The following is a description of a gene set: studied in species Homo sapiens Human Gene Set: GOMF_PLATELET_DERIVED_GROWTH_FACTOR_RECEPTOR_BINDING Binding to a platelet-derived growth factor receptor., and this is the list of marker genes: VEGFD, IL1R1, PDGFA, ERN1, PDGFRA, PDGFC, PTPRJ, PDGFB, ITGB3, PDGFD, LYN, VEGFA, ITGA5, PDGFRB